Given this list of marker genes UBE3A, SAFB, DAXX, IGF1, PKN1, ZDHHC7, KDM3A, FOXH1, CST11, AR, HDAC6, TCF7L2, SIRT1, TMF1, SFRP1, PARK7, SMARCA4, SCGB2A2, PRMT2, USP26, RHOA, PLPP1, PIAS2, ZMIZ1, EP300, RWDD1, NODAL, ZBTB7A, NCOR1, KDM1A, HDAC1, DAB2, DDX5, DDX17, SHQ1, NCOR2, FKBP4, FOXP1, PHB1 (prohibitin 1), RNF14, RHOXF1, TAF1, KDM5D, SAFB2, HEYL, PMEPA1, TRIM68, RNF6, SCGB2A1, TCF21, NKX3-1 (NCBI Gene Id 4824), KDM4C (NCBI Gene Id 23081), here is a description of the gene set: species: Homo sapiens A nuclear receptor-mediated signaling pathway initiated by an androgen binding to an intracellular receptor of the nuclear receptor protein family, and ending with regulation of a downstream cellular process, e.g. transcription. Human Gene Set: GOBP_ANDROGEN_RECEPTOR_SIGNALING_PATHWAY